Given this list of marker genes CASR, GRM4, GPRC5C, GPRC5B, GRM5, GRM8, GPRC5D, GRM6, GABBR2, GRM7, GRM1, GABBR1, GRM3, GRM2, GPRC5A, here is a description of the gene set: Human Gene Set: WP_GPCRS_CLASS_C_METABOTROPIC_GLUTAMATE_PHEROMONE species: Homo sapiens GPCRs, class C metabotropic glutamate, pheromone